The following is a description of a gene set: Mouse Gene Set: GOCC_GAMMA_SECRETASE_COMPLEX A protein complex that has aspartic-type endopeptidase activity and contains a presenilin catalytic subunit (either PSEN1 or PSEN2), an APH1 subunit (multiple genes and splice variants exist), nicastrin (NCT), and presenilin enhancer (aka PEN-2 or Psenen), as the core complex. Variants of the complex with different subunit compositions differ in localization and specific substrates. Additionally, variants of the complex exist that contain a additional regulatory subunit as well as the four core subunits; known regulatory subunits include gamma-secretase-activating protein (aka gSAP), TMP1 (aka TMED10), and CD147 antigen (aka basigin). Gamma-secretase cleaves type I transmembrane protein substrates, including the cell surface receptor Notch and the amyloid-beta precursor protein. species: Mus musculus, and this is the list of marker genes: Psen1 (NCBI Gene Id 19164), Tmed10-ps, Tmed10, Psenen, Psen2, Ncstn, Aph1c, Aph1b, Aph1a